The following is a description of a gene set: Reactome Pathway: NFG and proNGF binds to p75NTR When the co-receptor sortilin is present at the cell surface, proNGF preferentially interacts with a p75NTR:sortilin complex. Thus, proNGF, which does not bind TRKA, discriminates between TRKA and p75NTR, in cells that express both receptors. The same is true for proBDNF. Pro-neurotrophin binding to p75NTR:sortilin activates an apoptotic cascade, which may be involved in cell death after injury, and in neurodegenerative diseases such as Alzheimer's dementia. studied in species Homo sapiens part of: p75 NTR receptor-mediated signalling, and this is the list of marker genes: NGFR, SORCS3, NGF